The following is a description of a gene set: from publication Cui Y, Zheng Y, Liu X, Yan L, Fan X, Yong J, Hu Y, Dong J, Li Q, Wu X, Gao S, Li J, Wen L, Qiao J, Tang F (PMID 30759401) Human Gene Set: CUI_DEVELOPING_HEART_TRABECULAR_ATRIAL_CARDIOMYOCYTE studied in species Homo sapiens, and this is the list of marker genes: COL4A2, KIDINS220, RNPC3, FBN2, ASAH1, SPTBN1, ENTREP1, PGRMC1, SPCS2, TMX2, EDNRA, B2M, PCMT1, P4HA1, TTN, GJA5, LEPROT, APLP2, RDH11, AKAP9, LAMB2, SQLE, VCL, IGF2BP2, MACF1, HSP90B1, SCD, MALAT1, TNFRSF12A, MDK, ATP11A, CPE, SLC3A2, MARS1, PRSS35, PAM, NNT, TIMP3, B3GNT2, SURF4, DCBLD2, CYP2J2, ANKRD26, MEIS1, ANGPT1, PTPRK, NDUFB9, CYP51A1, TMEM41B, BMPR2, ARL6IP5, MYSM1, AGL, LTBP1 (NCBI Gene Id 4052), NCAM1, TMEM38B, LMAN1, NPTN, CPVL, SPINT2, MFSD11, NID2, HRC, LNPK (lunapark, ER junction formation factor), PPIC, GOLGA8A, CTSV, SLC11A2, COL2A1, ITGA6, SELENOT, AIFM1, CXADR, CALU, WLS, TRA2B, ZNF827, COL4A6, TCERG1, ETNK1, PRKDC, VEGFA, ASPH, C5orf15, FRAS1, REEP5, JAG1, EPRS1, TMTC3, SPTAN1, ADGRL2, DKK3, TMEM245, DAG1, PSAP, ERBB2, LMO7 (NCBI Gene Id 4008), INSR, BCAP29, FREM2, BSG, LGALS3BP, MTDH, CTSL, PLEKHA5, HERC2P2, TM9SF2, CACNA1C, SLC38A1, BLTP1, COL9A1, PRNP, PLXNB2, LAMP2, EMP2, HEG1 (NCBI Gene Id 57493), NES, LAPTM4B, GOLIM4, PDIA3, RPN2, GPAA1, CCNL1, SLC2A1, KCNH7, WSB1, COX6A1 (NCBI Gene Id 1337), KTN1, SLC8A1, SUCO, CDH2, OS9, DMD, NEU1, DST, SVIL, SLC20A2, DDX17, CANX (NCBI Gene Id 821), HSPA5, NOMO1, HEPH, XIRP1, GPC1 (NCBI Gene Id 2817), PTGFRN, MARCHF6, ITGB1, GRN, MESD, ATP6AP2, AKAP1, SLC16A1, TMBIM6, CD164, DNAJB9, DPY19L2, ATP1A1, MMP15, DSP, PARM1, BVES, RNF207, CD63, LUC7L3, ABCC5, PKN2, ATP2A2, RELN, FAT1, RTN4, MSMO1, PLOD2, COL18A1 (collagen type XVIII alpha 1 chain), TMED10, ATP1B1, TLCD4, FLNC, NFE2L1, ATP13A3